Given this list of marker genes IL6ST, IL6R, IL2, SMAD7, JUNB, STAT3, FOXP3, SOCS3, LGALS1, BRD2, NFKBIZ, IRF4 (NCBI Gene Id 4592), NFKBID, STAT5A, MIR21, JAK1, ZBTB7B, IL12RB1, IL23R, SLAMF6, BRD4, IL6, ENTPD7, RORC, EP300, TNFSF18, IL12B, RC3H2, BATF, OPA1, LY9, MALT1, JAK3, ZC3H12A, ASCL2, CD69, TBX21, RC3H1, IL23A, RORA, LOXL3, here is a description of the gene set: species: Homo sapiens Human Gene Set: GOBP_T_HELPER_17_CELL_DIFFERENTIATION The process in which a relatively unspecialized T cell acquires the specialized features of a T-helper 17 (Th17) cell. A Th17 cell is a CD4-positive, alpha-beta T cell with the phenotype RORgamma-t-positive that produces IL-17.